Given this list of marker genes Gabrb3, Slc1a1, Casp9, Kcnq1, Casp3, Gabrg2, here is a description of the gene set: species: Mus musculus Mouse Gene Set: GOBP_RESPONSE_TO_ANESTHETIC Any process that results in a change in state or activity of a cell or an organism (in terms of movement, secretion, enzyme production, gene expression, etc.) as a result of an anesthetic stimulus. An anesthetic is a substance that causes loss of feeling, awareness, or sensation.